Given this list of marker genes CA13, CA4, CA9, CA2, CA5B (carbonic anhydrase 5B), CA7 (NCBI Gene Id 766), CA14, CA6, CA12, CA1, CA3, CA5A, here is a description of the gene set: Reversible hydration of carbon dioxide Human Gene Set: REACTOME_REVERSIBLE_HYDRATION_OF_CARBON_DIOXIDE studied in species Homo sapiens